Given this list of marker genes Ccnf, Mdm1, Trim37, Npm1, Nubp1, Cdk5rap2, Rbm14, Kat2b, Kifc1 (NCBI Gene Id 21656), Tmem67, Kat2a, Cenatac, here is a description of the gene set: Any process that decreases the frequency, rate or extent of centrosome duplication. Centrosome duplication is the replication of a centrosome, a structure comprised of a pair of centrioles and peri-centriolar material from which a microtubule spindle apparatus is organized. Mouse Gene Set: GOBP_NEGATIVE_REGULATION_OF_CENTROSOME_DUPLICATION studied in species Mus musculus